Given this list of marker genes GPHN, NFS1, MOCS3, MOCS2, MOCOS, MOCS1, here is a description of the gene set: The chemical reactions and pathways involving a prosthetic group, the non-amino acid portion of certain protein molecules. Prosthetic groups may be inorganic or organic and are usually required for the biological activity of the protein. Human Gene Set: GOBP_PROSTHETIC_GROUP_METABOLIC_PROCESS studied in species Homo sapiens